The following is a description of a gene set: Genes up-regulated in cells (myoblast) by IGF1 vs PDGFB. Human Gene Set: KUNINGER_IGF1_VS_PDGFB_TARGETS_UP from publication Kuninger D, Kuzmickas R, Peng B, Pintar JE, Rotwein P (PMID 15475267) Peptide growth factors regulate cell fate by activating distinct signal transduction pathways that ultimately influence gene expression. Insulin-like growth factors (IGFs) play central roles in controlling somatic growth and participate in skeletal muscle development and regeneration. In cultured muscle cells, IGF action is critical both for maintaining viability during the transition from proliferating to differentiating myoblasts and for facilitating differentiation. By contrast, platelet-derived growth factor (PDGF) can sustain cell survival but inhibits differentiation. Here we examine the genetic programs that accompany IGF and PDGF action in myoblasts. Through analysis of high-density oligonucleotide arrays containing approximately 36,000 mouse probe sets, we identify 90 transcripts differentially induced by IGF-I, including 28 muscle-specific genes and 33 previously unannotated mRNAs, and 55 transcripts specifically stimulated by PDGF, including 14 unknowns. Detailed study of one IGF-induced mRNA shows that it encodes a protein related to a recently characterized repulsive guidance molecule postulated to regulate neuronal targeting during development. Our results demonstrate the power of transcriptional profiling for gene discovery and provide opportunities for investigating new proteins potentially involved in different aspects of growth factor action in muscle. species: Mus musculus, and this is the list of marker genes: FST (NCBI Gene Id 10468), GATM, SGCG, ERBB3, SNTB1, DDC, LMOD2, ACTC1, USP2, HJV (NCBI Gene Id 9974), UNC45B, ZBTB18, AAMDC, FBXO17, SRL, FNDC5, KLHL40, CNR1, BRWD1 (bromodomain and WD repeat domain containing 1), TNNT2, IGF2, PABPC1L, ITGB1BP2, FMO1, ENAH, SYNPO2L, MYL1, NCAM1, SGCA, SMYD1, C1QTNF3, LDB3, TPM1, TNNI1, TMEM182, MYLK4, PYGM, MYOG, NEIL1, DCLK1, MYBPH, SMTN, CAVIN2, TTN, COX6A2, GPT2, SMPX, PRKAG3, ACTA1, MYMX, PARM1, ATP2B4, TPM2, TNNT1, HSPB2, RB1 (NCBI Gene Id 92728), MYL4, FZD5, PKIA, PPFIA4, PGAM2, HDAC11, STYXL2, NPNT, DAAM2, MYH3, PRKAA2, USP3, TMEM38A, KLHL41 (kelch like family member 41), TNNC1, ACTN3, FAM8A1, IFFO1, CCDC134, ATP2A1, RYR1, XIRP1, MYOM2, TNNT3, MYMK, SOX8